The following is a description of a gene set: studied in species Homo sapiens A network of proteins adjacent to the postsynaptic membrane. Its major components include the proteins that spatially and functionally organize neurotransmitter receptors in the adjacent membrane, such as anchoring and scaffolding molecules, signaling enzymes and cytoskeletal components. Human Gene Set: GOCC_POSTSYNAPTIC_SPECIALIZATION_INTRACELLULAR_COMPONENT, and this is the list of marker genes: BAIAP2, CTNNB1, PSD, CFL1, SLC30A1, SIPA1L3, FAM81A, PRR7, GRID2IP, NSF, SH3GL3, FABP5, ZDHHC5, GPHN, PTK2B, USP6, FYN, ACTN2, CTNNA2, LYN, CRIPT, GRIA1, TNIK